Given this list of marker genes Eif3d, Rb1, Hmgb2, Igf1, Ep300, Vtn, Aktip, Egf, Mark3, Foxc1, Pin1rt1, Hipk2, Lamtor5 (late endosomal/lysosomal adaptor, MAPK and MTOR activator 5), Abl2, Ufl1 (NCBI Gene Id 67490), Met, Gmnn, Agrn, Txn1, Trim21, Dact1, Mmp9, Epha4, Spta1, Trib3, Ebf2 (early B cell factor 2), Twist1, Krit1, Rara, Tunar, Ddx11, Ifng, Tcf7l2, Bmp4, Ephb6, Irf4, Nvl, Ran, Ip6k2, Epb41, Ripor2, Pinx1, Ski, Myod1, Hand2, Mapre3, Bmp2, Isl1, Rpl11, Neurod1, Eno1, Med25, Smarca4, Trim28, Parp9, Tiam1, Ralb, Gpsm1, Gata3, Tmem132a, Dtx3l, Brd4, Pitx2, Trim6, Usp33, Anxa2, Plaur, Cln5, Epb41l5, Ctbp2, Hmgb1, Gsk3b, Nphp3, Sting1, Ripk2, Ngf, Pin1 (peptidyl-prolyl cis/trans isomerase, NIMA-interacting 1), Ncbp1, Plxnd1, Pygo2, Add2, Ripor1, S100a10, Rapgef2, Arhgef7, Lfng, Cdt1, Ide, Prkn, Zfp618, Eif3e, H1f0, Blk, Dazap2, Edf1, Ticam1, Plcl2, Tert, Pou4f2, Myocd, Calm1, Cldn5, Dph3, Cdk5, Pou4f1, Eif2ak3, Nmd3, Hip1r (huntingtin interacting protein 1 related), Traf6, H2bc1, Flot1, B2m, Park7, Lrrk2 (NCBI Gene Id 79409), Rfng, Cthrc1, Spag8, Pax6, Sirt2, Abl1, Plcl1, Mfng, Tgfb2, Hfe, Hes1, Bdnf, Eif4g1, Fam220a, Spon1, Add1, Mapre1, Tns3, Niban2, Nme1, Ddrgk1, Stmn1, Kdm4d, Ercc2, Bambi, Usp9x, Hipk3, Wnt5a, Lrp1, Hipk1, here is a description of the gene set: Mouse Gene Set: GOBP_POSITIVE_REGULATION_OF_BINDING species: Mus musculus Any process that activates or increases the rate or extent of binding, the selective interaction of a molecule with one or more specific sites on another molecule.